The following is a description of a gene set: species: Homo sapiens Any apoptotic process in a T cell, a type of lymphocyte whose defining characteristic is the expression of a T cell receptor complex. Human Gene Set: GOBP_T_CELL_APOPTOTIC_PROCESS, and this is the list of marker genes: BAX, ST3GAL1, RIPK1 (NCBI Gene Id 8737), BCL2, DNAJA3, SIVA1, BBC3 (NCBI Gene Id 27113), LGALS16, LIPA, ADA, PRELID1, GIMAP8 (NCBI Gene Id 155038), HIF1A, EBF4, TP53, TGFB2, IL2RA, RAG1, LMBR1L, PRKD2, RORC, JAK3, BCL11B, DOCK8, BCL2L11, ZC3H8, PIP, ADAM8, PRKCQ, SLC46A2, WNT5A, FADD, EFNA1, AKT1, IDO1, CHEK2 (NCBI Gene Id 11200), IL7R (NCBI Gene Id 3575), CD274, CLC, BCL10, BCL3, P2RX7, BMP4, RIPK3, ARG2, PDCD1, BAK1, FAS, LGALS3, DFFA, KDELR1, GPAM, KIFAP3, CD27, LGALS9, PERP, PTCRA, FASLG, CCL5, TSC22D3, GLI3